The following is a description of a gene set: Ectodysplasin A signaling in hair follicle development Mouse Gene Set: WP_ECTODYSPLASIN_A_SIGNALING_IN_HAIR_FOLLICLE_DEVELOPMENT studied in species Mus musculus, and this is the list of marker genes: Sostdc1, Ptch1, Dkk1, Edaradd, Rela, Ltb, Nfkb1, Eda, Nfkb2, Relb, Edar, Gli1, Shh, Dkk4